The following is a description of a gene set: species: Mus musculus Any process that stops, prevents, or reduces the frequency, rate, or extent of production of transforming growth factor-beta. Mouse Gene Set: GOBP_NEGATIVE_REGULATION_OF_TRANSFORMING_GROWTH_FACTOR_BETA_PRODUCTION, and this is the list of marker genes: Tyrobp, Cd2ap, Fn1, Tsku, Laptm4b, Cd24a, Met (NCBI Gene Id 194383), Il13, Fbln1, Furin, Gata6